Given this list of marker genes Psmd11, Ifi27l2b, Hs2st1, Gabrp, Calu, Lat2, Ep300, Defb12, Samd4, Atcay, Zfp987, Mat1a, Pmm2 (phosphomannomutase 2), Prop1, Cfap43, Lrrc38, Ppp2r2a, Zfp629, Zfp114, Zdhhc14, Pip4k2a, Ddx1, Arf6, Camta1, Fgf1, Nos1, Cyrib, Pcca, Stx11, Ctbp2, Vangl2, Selenos, E2f4, Grm5, Cd14, Kifap3, here is a description of the gene set: Genes predicted to be targets of miRBase v22 microRNA mmu_miR_7017_5p in miRDB v6.0 with MirTarget v4 prediction scores > 80 (high confidence targets). from publication Chen Y, Wang X (PMID 31504780) studied in species Mus musculus Mouse Gene Set: MIR_7017_5P